Given this list of marker genes Tirap, Tlr2, Ripk2, Cd36, Rela, Tlr4, Lbp, Cd14, Mapk14, Trem2, here is a description of the gene set: Any process that results in a change in state or activity of an organism (in terms of movement, secretion, enzyme production, gene expression, etc.) as a result of a lipoteichoic acid stimulus; lipoteichoic acid is a major component of the cell wall of gram-positive bacteria and typically consists of a chain of glycerol-phosphate repeating units linked to a glycolipid anchor. studied in species Mus musculus Mouse Gene Set: GOBP_RESPONSE_TO_LIPOTEICHOIC_ACID